The following is a description of a gene set: part of: Signaling by NTRK1 (TRKA) This event has been computationally inferred from an event that has been demonstrated in another species.<p>The inference is based on the homology mapping from PANTHER. Briefly, reactions for which all involved PhysicalEntities (in input, output and catalyst) have a mapped orthologue/paralogue (for complexes at least 75% of components must have a mapping) are inferred to the other species. electronically inferred by orthology from the curated human pathway studied in species Mus musculus Reactome Pathway: Activation of TRKA receptors, and this is the list of marker genes: Ngf